Given this list of marker genes PTTG1IP, MBNL3, SMG1, VTA1, SCARF1, ARSJ, CRIPT, PCDH9, AIDA, KLHL28, ENAM (enamelin), ZNF197, ZFP82, ALG9, LSM12, DERA, DCAF8L1, JMY, SEPTIN7, CBX3, VAMP2, LIN54, ADAMTS1, IPP, SPAG1, DDX5, GPM6A, ATRX, NUP133, FRY, MEX3A, NALF1, ABCA13, SH2D1B, SLAIN2, FBXO30, PAIP1, SGCD, BTK, ELOC, PAK5, NEXMIF, PIGX, DELEC1, BEND4, ZNF606, TRIM9, TIMM8A, STK4, HIRA, PIP5K1B (phosphatidylinositol-4-phosphate 5-kinase type 1 beta), RICTOR, ITCH, ARFGEF3, DGKI, EPHA7, TUT4, ZNF449, SMCHD1, SLC40A1, KLB, RBFOX2, CR1, MAMDC2, ZBTB10, PDCL (NCBI Gene Id 51420), TBL1XR1, MS4A6A, ALKAL1, CPSF6, PPP3CB, ZNF300, FCHO2, FAM47C, SINHCAF, RCN1, ARMCX3, POLK, HSPBAP1, ZBED4, RBM41, NSL1, MED23, NEPRO, RCCD1, here is a description of the gene set: species: Homo sapiens from publication Chen Y, Wang X (PMID 31504780) Human Gene Set: MIR628_3P Genes predicted to be targets of miRBase v22 microRNA hsa-miR-628-3p in miRDB v6.0 with MirTarget v4 prediction scores > 80 (high confidence targets).